The following is a description of a gene set: Bulbar palsy Human Gene Set: HP_BULBAR_PALSY Bulbar weakness (or bulbar palsy) refers to bilateral impairment of function of the lower cranial nerves IX, X, XI and XII, which occurs due to lower motor neuron lesion either at nuclear or fascicular level in the medulla or from bilateral lesions of the lower cranial nerves outside the brain-stem. Bulbar weakness is often associated with difficulty in chewing, weakness of the facial muscles, dysarthria, palatal weakness and regurgitation of fluids, dysphagia, and dysphonia. species: Homo sapiens, and this is the list of marker genes: DNAJB6, MYO9A (NCBI Gene Id 80251), SLC5A7, SQSTM1 (NCBI Gene Id 94002), SLC52A3, ATXN1, SLC25A1, DOK7, AR, RTN2 (NCBI Gene Id 6253), DES, TPM3, SLC18A3, TIA1, AGRN, TARDBP, TBK1, CHAT, SYT2, VCP, BICD2, ARSA, CHRNE, PLAA, TK2, CHCHD10, HK1, NEB, COL13A1, ABCD1, MTRFR, SLC52A2, MATR3, CHRNA1, ACTA1, GIPC1, SNAP25, GSN, FUS, VAMP1, TRPM7, LMOD3, PET100